Given this list of marker genes BUB1, NSMCE2, PLK1, SMC1A, SMC1B, FEN1, RAD21, ESPL1, MAU2, POGZ, REC8, SMC3, PPP2R5D, PDS5B, ATRX, NAA10, ESCO2, KIF22, TNKS, HORMAD2, STAG2, DDX12P, NIPBL, SLF1, CHTF8, DDX11, MACROH2A1, TENT4A, BUB1B, CTCF, STAG1, PPP2R1A, CDCA5, HDAC8, RAD21L1, PPP2R5C, PHB2, SLF2, RAD51C, SGO2, MRE11, HASPIN, GTF2B, WAPL, CTNNB1, SGO1 (NCBI Gene Id 151648), HORMAD1, SMC5, DSCC1, PPP2R1B, ESCO1, PDS5A, NAA50, AXIN2, SFPQ, BOD1, DDX11L8, MCMBP, MEIKIN, FBXW7, RB1, CDC20 (cell division cycle 20), STAG3, here is a description of the gene set: Human Gene Set: GOBP_SISTER_CHROMATID_COHESION species: Homo sapiens The cell cycle process in which the sister chromatids of a replicated chromosome become tethered to each other.